The following is a description of a gene set: Malignant mesothelioma is an aggressive neoplastic proliferation derived from cells lining serosal membranes. The biological and clinical characteristics of epithelial type malignant mesothelioma are distinct from those of biphasic and sarcomatous type tumors. The goal of our study was to examine the molecular basis for this distinction. Microarray analysis confirmed that the molecular signatures of epithelial and biphasic histologic subtypes were distinct. Among the differentially expressed functional gene categories was the ubiquitin-proteasome pathway, which was upregulated in biphasic tumors. Cytotoxicity experiments indicated that 211H cells derived from biphasic tumors were synergistically sensitive to sequential combination regimens containing the proteasome inhibitor bortezomib and oxaliplatin. The mechanism of this synergistic response, which was not detected in cells of epithelial tumor origin, was apoptosis. Together, our results identify the ubiquitin-proteasome pathway as a biomarker of poor prognosis biphasic peritoneal mesothelioma tumors and suggest that proteasome inhibitors could increase the effectiveness of cytotoxic chemotherapy in this subset of patients. species: Homo sapiens Human Gene Set: BORCZUK_MALIGNANT_MESOTHELIOMA_UP from publication Borczuk AC, Cappellini GC, Kim HK, Hesdorffer M, Taub RN, Powell CA (PMID 16862182) Genes up-regulated in biphasic (mixed) vs epithelial subtypes of malignant peritoneal mesothelioma., and this is the list of marker genes: WTAP, RALA, ZNF318, RAD1, DOCK1, NME1, TGFB1, VAMP3, PIGC, PSMB7, ERGIC3, SRSF10, F8A1, GTF2A2, S100A11, RHOBTB3, FKBP4, IARS2, RCOR1, TOP2A, VRK2, ANXA2, COPA, SERBP1, HSPA4, CHTOP, RP2, CCT5, CSNK1D, SKP1, YWHAQ, CALD1, CPQ, SLC25A1, DBI, DDX18, MED21, DESI2 (desumoylating isopeptidase 2), ADNP (activity dependent neuroprotector homeobox), ACBD3, PSMA2, RARS1, WSB2, FADS1, LDOC1, UROS, UBE2S, KIF11, ISG20L2, ZBTB14, SCAMP3, TMEM183A, SCCPDH, PAPOLA, AHCY, AZIN1, MRPL28, FKBP1A, PARP1, GLO1, MSMO1, POMK, CENPS, MFN1, RO60, BET1, TERF1, SEC24D, MPZL1, NEK4, RAF1, PPP1R2, TMED7, ITGAV, SEC23IP, SMARCC1, UBE2D1, UTP25, IPO7, FBL, ACAP2, RPS6KA3 (ribosomal protein S6 kinase A3), PPP4C, MAGED1, UBE2G1, PAK2, SDHB, STAT3, TUBA3E, KIF2A, SSBP1, ATP5F1A, LAMP2, RFC4, THAP11, CCT3, MRPL3, TNPO1, RPA1, LAMC1, ATP2A2, XRCC5, UBQLN2, CDKN2C, PKM, RAB4A, FZD6, PCLAF, RIT1, NCBP2, MPC2, OSMR, SMC4, ZWINT, WEE1, CCT2, STK17A, RCN2 (NCBI Gene Id 5955), HPRT1, PARK7, RAN, PARVB, PRPS2, GRB2, NAP1L1, DBN1, THBS2, SEC61G, ACTL6A, UBA2, RIF1, MACIR, COPS5, CALU, TUBA1A, BPHL, TAF11, SMC1A, TAF12, TK1 (NCBI Gene Id 7083), KRT10, QKI, NUDT1, RAP1B, PLD3, SRD5A1 (steroid 5 alpha-reductase 1), VBP1, METTL18, DKC1, CCNE2, MTCP1, KDM1A, SMAD2, UBE2D3, HNRNPC, MAP2K1, ARL1, DYNLT3, ILF2, BLMH, EPRS1, MAPRE1, SRPK2, CBX3, DNAJA1, ZMYND11 (NCBI Gene Id 10771), PNO1, MORF4L2 (mortality factor 4 like 2), PABPC1, SNRPF, NHP2, CCZ1, RAP1GDS1, PPT1, HDGF, LUM, CCNG1, MAPKAP1 (MAPK associated protein 1), TFDP1, TUSC3, H2AZ1, BICD2, CAPN7, HSPA8, SMAD4, MSH6, ARPC4, PRPSAP2 (phosphoribosyl pyrophosphate synthetase associated protein 2), VAMP7, P4HA1, MCM6, UBXN7, PCMT1, PRRC2C, LAMTOR5, DUSP7, FTSJ1, SMAD5, USP9X, FNTA, MOB1A, HIPK1, RAC1, FSCN1, MACROH2A1, CRABP2, SRSF3, DDOST, UBE2A, EMG1, RAB32, STIP1, CKS2, CKS1B, TPX2, GARS1, F2R, TUBA3C, AP2S1, CDK7, UBE2C, BUB1B, FLNA, RFC2, PSMD10, LINC00869, SRSF1, SQLE, MAD2L1, CDC27, LYPLA1, CCNB1, H2AZ2, NCK1, RASA1, JTB, G3BP1, CNOT8, SKIC3, CGRRF1, PSMD2, TAF5L, RNF2, DENND5A, KPNA2, CDC42BPA, BLVRA, SRPK1, SAP30, PGRMC1, TMEM97, HMGA1, GDI2 (GDP dissociation inhibitor 2), NDUFS2, LPGAT1, KIF5B, MAPK9, PYCR1, SSR1, AP3B1, LIN37, SMNDC1, KIFAP3, HACD2, PSMD8, CCNF, QSOX1, RBBP4, TRIAP1, GINS1, S100A2, KIFBP, SS18, EIF3H, DCK, RAP1A, CDK4, RPS15A, EIF3I, VDAC1, PRKCA, SELENOW, PDCD6, BUB3, PGK1, PCNA, SLC25A3, UBE2E3, COA1, PRKDC, XPOT (NCBI Gene Id 11260), UBE2D2, PUF60, PTGES3, ELOC, MAPKAPK2 (MAPK activated protein kinase 2), PRDX4, YKT6, CREBBP, YWHAZ, UBE2N, UBAP2L, LOXL2, PSMB6, RAB1A, KDM5B, RAD21, KRIT1, HSP90AB1, MAGED2